The following is a description of a gene set: The cell cycle process in which the sister chromatids of a replicated chromosome are joined along the entire length of the chromosome, from their formation in S phase through metaphase during a mitotic cell cycle. This cohesion cycle is critical for high fidelity chromosome transmission. Mouse Gene Set: GOBP_MITOTIC_SISTER_CHROMATID_COHESION studied in species Mus musculus, and this is the list of marker genes: Macroh2a1, Bub1, Pttg1, Pogz (pogo transposable element with ZNF domain), Slf2, Dscc1, Pds5b, Cdk11b, Chtf8, Nsmce2, Slf1, Smc5, Naa10, Mau2, Cdca5, Esco2, Cdc20, Hdac8, Tnks, Haspin, Atrx, Pds5a, Esco1 (establishment of sister chromatid cohesion N-acetyltransferase 1), Smc3, Nipbl, Naa50, Sgo1, Rb1